Given this list of marker genes KIF1B, SDHA, MDH2, SDHB, TMEM127, SCN2A, FH, MAX (NCBI Gene Id 4149), SDHD, EPAS1, SLC25A11, DNMT3A, NF1, DLST, SDHAF2, RET, VHL, SDHC, CACNB4, here is a description of the gene set: Paroxysmal vertigo species: Homo sapiens Paroxysmal episodes of vertigo. Human Gene Set: HP_PAROXYSMAL_VERTIGO